The following is a description of a gene set: studied in species Mus musculus Genes positively differentially expressed in cell type: NK cell upon treatment with cytokine: GM-CSF in mouse lymph nodes in vivo. from publication Cui A, Huang T, Li S, Ma A, Pérez JL, Sander C, Keskin DB, Wu CJ, Fraenkel E, Hacohen N (PMID 38057668) Cytokines mediate cell-cell communication in the immune system and represent important therapeutic targets. A myriad of studies have highlighted their central role in immune function, yet we lack a global view of the cellular responses of each immune cell type to each cytokine. To address this gap, the authors created the Immune Dictionary, a compendium of single-cell transcriptomic profiles of more than 17 immune cell types in response to each of 86 cytokines (>1,400 cytokine-cell type combinations) in mouse lymph nodes in vivo. A cytokine-centric view of the dictionary revealed that most cytokines induce highly cell-type-specific responses. For example, the inflammatory cytokine interleukin-1β induces distinct gene programmes in almost every cell type. A cell-type-centric view of the dictionary identified more than 66 cytokine-driven cellular polarization states across immune cell types, including previously uncharacterized states such as an interleukin-18-induced polyfunctional natural killer cell state. Mouse Gene Set: CUI_NK_CELL_GM_CSF_RESPONSE_UP, and this is the list of marker genes: Fcer1g, Mcrip1, Hspa5, Aph1a, Atp5mf, Arpc1b, Snx3, Atp5pf, Calr, Arf1, Uchl3, Farsa, Dctn5, Ppp1r35, Pdia6, Oxa1l, Lgals1, Septin7, Snx6, Serpinb9 (NCBI Gene Id 20723), Flna, Coro1a, Hnrnph3, Cfl1, Ptprcap, Spn, Gzmb, Ssbp1, Mrpl4, Phb1, Slamf7, Tram1, Selenof, Fkbp1a, Chmp2b, Blvra, Sptlc2, Taldo1, Rnh1, Gstp1, Timm8a1, Slc25a5, Anp32a, Txndc9, Myo6, Eif5, Gzma, Cetn3, Tubb4b (tubulin, beta 4B class IVB), Tomm22, Rhof, Rbm14, Ndufb3, Cotl1, Tmed9, Romo1, Ebp, Tmbim4, Scimp, AB124611, Spin2c, Prr14l, Mrpl21, Kcnj8, Pfn1, Ppp1r7, Ndufa1, Pgls, Myl12a, Rhoc, Idh3a, Cdc37, Gle1, Ube2i